Given this list of marker genes FOXC1, SC5D, ANKRD55, PCSK9 (NCBI Gene Id 50983), B4GAT1 (NCBI Gene Id 11041), NTRK1, TRAPPC2, CD247, RIPK4, STAT4 (signal transducer and activator of transcription 4), DDB2, LCAT, GLB1, LZTR1, APOE, ERCC2, PEX1, PITX3, AIRE, IDUA, SLC29A3, ERCC8, CHST6, FOXE3, WT1, WDR73, NDP, GALNS, VSX2, CTSA, FLG, CPAMD8, LDLR, GNAS, XPC, SLC4A4, COL8A2, GRHL2, APOA2, COL18A1, ERCC4, PEX5, SREBF1, RAB23, CYP1B1, NLRP3, GHR, GNPTAB, PTPN2, PTPN22, GBA1, TGFBI, PSMB8, MBTPS2, UBIAD1, APOA1, CHRDL1, POMGNT1, PEX2, KRT12, NAGA, IL2RA, SMARCAL1, STS, ERCC5, VSX1, PDGFRB, JAG1, KRAS, PPP1R17, SLC4A11, TEK, GNPTG, LIPC, MMP2, TRPV3, TRPV4, LTBP2, ALDH18A1, ZEB1, PRDX3, NOD2, MYOC, ERCC3, LIFR, CYP4V2, XPA, OVOL2, IL2RB, TCF4, ABCG8, ASAH1, ESCO2, KERA, OCLN, MCOLN1, TACSTD2 (tumor associated calcium signal transducer 2), ABCA1, EPHX2, PITX2, APOB, ERCC6 (ERCC excision repair 6, chromatin remodeling factor), PAX6, CTNS, SOS2, here is a description of the gene set: Abnormal corneal stroma morphology Human Gene Set: HP_ABNORMAL_CORNEAL_STROMA_MORPHOLOGY An abnormality of the stroma of cornea, also known as the substantia propria of cornea. studied in species Homo sapiens